Given this list of marker genes CDIP1, SATB1, RPL7, TOM1L2, BTG1, UBN2, RFLNB, H2BC13, MATK, SUPT3H, SEPTIN6, RBM6, ECE2, ALDH1B1, STAT6, COX7A2L, ZNF622, AGRN, RPL19, CD53, EVL, RPL35, SSH2, UBR2, USE1, IER5, EPS8L1, ALS2CL, PSME1, TSACC, GALNT6, RNF213, IL6R, ZNF566, B3GALNT2, SARAF, GON4L, VPS8, WDR59, RAB12, BCL11B, RPL31, DCDC2B, SNORD104, FITM2, FAS, SRRM2, IFT88, UBN1, SDF4, ZNF710, SCP2, PIK3IP1, TNFAIP8L2, TCN2, TNFRSF1A (NCBI Gene Id 8077), SMAD4, RASAL3, RCN3 (NCBI Gene Id 57333), DCAF11, C21orf91, RPLP2, RPS27, SMYD3, DEDD2, DNAJC17, ABTB1, ELANE, BCKDHA, VPS37B, LAT, SOCS3, PIGV, PPP1R13B, INHBB, RIOK2, PNRC1, SLC37A1, ID3, DZIP1, LIMD1, RPS21, CRTC1, OAZ2, CCM2, USPL1, IL6ST, SNHG12, CIMIP1, BACE1, UBLCP1, HAGH, ARHGAP39, IDS, RPL11, TCP11L2, ZBTB26, IL27RA, CARD6, TMEM258, RPL22, KLF13, SLC14A1, KLK8 (NCBI Gene Id 116193), ARL4C, PCYT2, GIMAP6, SLC49A4, NCOA2, SH3GL1, IRF2BP2, YEATS4, TMEM259, STIM1, APPL2, AFG1L, PRR27 (proline rich 27), UBAC2, ADGRG5, MAPDA, WLS, IGFBP4, CCND2, ORMDL3, NRN1L, DUSP11, CORO1A, RPS7, NXF1, ANKRD10, DNMBP, RPS14, VEGFB (vascular endothelial growth factor B), RNF130, NINJ1, CNP, CTU2, RNF11, RPL24, RPS11, RPL13, TMEM71, RPL38 (ribosomal protein L38), ACP6, UST, ARID5A, PITX3, NAP1L2, RASGRP1, PDE7A, MTERF4, SLFN12L, THYN1, TXNIP, SIPA1L2, ACVR1B, TCF7, RING1, ZNRF1, NPHS2, HMGXB3 (NCBI Gene Id 22993), LPAR6, FOXO1, QPRT, TPT1, CCDC102A, CHST15, RPL26, BACH2, EEF1B2, RHOA, PPIC, NTPCR, BMF, TEX264, PIK3R4, RSRP1, AMPD1, ST8SIA1, RPL36, ENG, MEA1, TGIF2, GLG1, TMEM108, MLYCD, SH3BP5 (SH3 domain binding protein 5), CD247, LAPTM4B, RPL27A, SELPLG, HLA-E, NEURL2, ABTB3, STK4, STX1A, OCEL1, TREML2, AKAP8L, here is a description of the gene set: Genes up-regulated in comparison of naive CD8 T cells versus effector CD8 T cells KLRG1 high. Using killer cell lectin-like receptor G1 as a marker to distinguish terminal effector cells from memory precursors, we found that despite their diverse cell fates both subsets possessed remarkably similar gene expression profiles and functioned as equally potent killer cells. However, only the memory precursors were capable of making IL-2 thus defining a novel effector cell that was cytotoxic, expressed granzyme B, and produced inflammatory cytokines in addition to IL-2. This effector population then differentiated into long-lived protective memory T cells capable of self-renewal and rapid re-call responses. Mechanistic studies showed that cells that continued to receive antigenic stimulation during the later stages of infection were more likely to become terminal effectors. Importantly, curtailing antigenic stimulation towards the tail-end of the acute infection enhanced the generation of memory cells. These studies support the decreasing potential model of memory differentiation and show that the duration of antigenic stimulation is a critical regulator of memory formation Human Gene Set: GSE10239_NAIVE_VS_KLRG1HIGH_EFF_CD8_TCELL_UP studied in species Homo sapiens from publication Sarkar S, Kalia V, Haining WN, Konieczny BT, Subramaniam S, Ahmed R (PMID 18316415)